Given this list of marker genes PLAUR, ANPEP, PSMA2, IRAK3, UBE2L6, PMCH, PSMD1, HMGCS1, CKS1B, PPP1R3D, TRAFD1, SGCG, MCOLN1, EIF3J, ARID5B, ACTL7B, ENG, TRIB1, CTSH, TRAF6, NXT2, PITPNA, TPM4 (NCBI Gene Id 7171), ZBTB43, PSMB7, NSUN3, EVI2A, PIWIL1, SGPL1, TRIM14, HILPDA, SPRED2, H2BC4, GNAI3 (G protein subunit alpha i3), RAB33A, UFD1 (ubiquitin recognition factor in ER associated degradation 1), EPAS1, PPP1R17, HSPA13, PTGS2, IER5 (immediate early response 5), ZBP1, ERP44, SRP9, ZC3H12A, APH1B, IL17A, PPP1R16B, ZW10, CABYR, TUBB3, ADM, TIMM17A, NBN (nibrin), LIG4, GBA1LP, GTF2I, LAP3, COQ7 (coenzyme Q7, hydroxylase, NCBI Gene Id 51672), ETNK1, RABIF, PI4K2A, KIF18A, H1-0, BTG3, IFITM2, MRPL42, HAS2, ZNF207, MT1X, LMBRD1, GAL3ST4, PLA1A, DHX58, SP3, JADE3 (jade family PHD finger 3), OGFRL1 (opioid growth factor receptor like 1), TRAPPC3, ACP2, PLAGL2, IRF7, SZRD1, LAMP2, ARC, FCAR, HSD11B1, TMX1, TNFSF14, RAPGEF5, C1GALT1, RAB21, TMOD3, ADM2, SLC11A2, ETS2, GLRX3, PDCD4, TXNDC9, QPCT, ARF4, KLHL21, PSMB8, GLUL, PNN, NRIP3, NETO2, WSB2, TTC33 (NCBI Gene Id 23548), PPP2CB (NCBI Gene Id 5516), IKZF3, TCN1, CPM, SHFL (NCBI Gene Id 55337), AQP9, SGMS1, SINHCAF, PDCD6, MXD1, FICD, MRM1, VRK2 (VRK serine/threonine kinase 2), FKRP, COQ10B, VCP, FYCO1, KIFBP, ZNF696, GRIA3, STIMATE, LAMTOR3, ELOC, CCL23, CGGBP1, NF1, CENPS, OR7E87P, CYBA, MT1E, ZNF45, CERT1, ADAM9 (NCBI Gene Id 8754), FBN1, NAPA, SLITRK3, TNF, CSRNP2, AKR1C2, ARFGAP3, COX17, C2orf49, RNF19B, NR3C1, ARPC3, FBXL12 (NCBI Gene Id 54850), ALOX15B, IGF2R, MXRA7, KIAA0408, MED28, C6orf62, SEMA3E, FASTKD3, ATP6V1H, ENPP2 (NCBI Gene Id 5168), TIGAR, PDE4A, RBCK1, RAB31, ZNF134, IRS1, RENBP, MT2A, HAMP, MYC, SDCBP, PSMC4, TMEM185B, PILRA, TMEM50A, MARCKSL1, IRF2, APOL1, SERPINB8, ASCL3, PDXDC1, RAD51D, GIMAP6, GTDC1, LNPEP, TSPAN6, SNRPB, LDHA, NDP, ARL3, MRC2, FAM114A2, FOXB1, SLC5A3, ADAR, CLUAP1, here is a description of the gene set: Human Gene Set: GSE13484_UNSTIM_VS_12H_YF17D_VACCINE_STIM_PBMC_DN from publication Querec TD, Akondy RS, Lee EK, Cao W, Nakaya HI, Teuwen D, Pirani A, Gernert K, Deng J, Marzolf B, Kennedy K, Wu H, Bennouna S, Oluoch H, Miller J, Vencio RZ, Mulligan M, Aderem A, Ahmed R, Pulendran B (PMID 19029902) The immune responses generated by YF-17D by profiling genes in PBMCs from 2 donors cultured with YF-17D vaccine were accessed after 3 and 12 hours. studied in species Homo sapiens Genes down-regulated in comparison of unstimulated peripheral blood mononuclear cells (PBMC) cultured for 0 h versus PBMC cultured for 12 h with YF17D vaccine.